The following is a description of a gene set: Genes containing one or more binding sites for (Eed) in their promoter regions (TSS -1000,+100 bp) as identified by GTRD version 20.06 ChIP-seq harmonization. Mouse Gene Set: EED_TARGET_GENES from publication Yevshin I, Sharipov R, Kolmykov S, Kondrakhin Y, Kolpakov F (PMID 30445619) studied in species Mus musculus, and this is the list of marker genes: Otx2, Rab8b, Gm9979, Cers2, 4932441J04Rik, Col13a1, Ret, Ankrd33b, Mymx, Lfng, Nppc, Gfra2, Hrh3, Shisa3, Gm8357, Gm5069, Hand2os1, Gata5, Klf14, Nsg1, Kctd15, Kdm6b, Matk, Kcnk15, Ntn4, Dysf, Gm9884, Nt5c2, Ankrd34b, Slc24a4, Emilin3, Drd5, Gm15723, Hand2, Igf2os, Gnas, Plekhd1os, Fgf5, Gm12198, Foxf1, Nr2f1, D030055H07Rik, Gm29543, Mcidas, mt-Ty, Atxn1, Gm12426, Mcc, Gm11240, mt-Tc, Hmx1, Cacna1c, Gm27032, Cacng4, Tor1aip1, Cacna2d3, Rai14, A830082K12Rik, Cbx2, Fpgs, 3110070M22Rik, St8sia6, Gm13162, Syt2 (NCBI Gene Id 96937), Pak6, Kcnc1, mt-Nd1, Osbpl6, Plxdc2, B4galnt2, H3f4, Ush1g, Six1, Lyzl4, Dipk1c, 1700039E22Rik, Gpr83, Lhx5as1 (NCBI Gene Id 102634380), Ntng1, Irx3os, Slc6a20a, Runx2, Pcdh9, Bhlhe41, Ebf3, 2900005J15Rik, Nr5a1, Tbc1d4, Rasgef1b, Pcdh7, Ctcf, Dll1, Cpne8, Gm2018, Tbc1d30, Rgs10 (NCBI Gene Id 67865), Gata6os, Cacna1g, Rxrg, Prob1 (NCBI Gene Id 381148), Mir8104, mt-Nd2, Zbtb20, Tlcd4, Aspa, Ptger4, Celf4, Itln1, Sema4b, Hoxa9, Adgrl3, Prok2, Slc25a48 (NCBI Gene Id 328258), Prr18, Kcnk9, Elobl, Trp73, Pantr2, Mpp2, Gm14343, Camkk1, Slc30a2, 1700028E10Rik, Nos1, Mir7652, Rnf217, Marveld3 (NCBI Gene Id 73608), Gm13830, A230077H06Rik, Slitrk3, Bcl11a, B130034C11Rik, Metrnl, Zhx2, Slc9a2, Trpc4, 2810032G03Rik, Pear1, Mras, Fibcd1, Adgrb3, Ttc39aos1 (NCBI Gene Id 102642299), Npy, Elfn2, Gm26583, Foxl2, Gm20426, Sp140l2, Nol4, Speg, Fhdc1, Wnt11, Grem1, Cbx3, Vsir, Atp8b1 (NCBI Gene Id 54670), Pianp, Gm16675, Lypd6b, Dchs1, Trim47, Nell1, A730035I17Rik, Hsp90aa1, Flt3, Galnt16, Zbtb46, Ttc34, Ano4, Skor2, Pradc1, Kirrel3, Oxtr, Rasgrf1, Rai1, Gprc5c, Gm10129, Alcam, Syt10, Gm16505, Spag6 (sperm associated antigen 6), Slc35d3, 4930570G19Rik, D430041D05Rik, Adam33, 4930426L09Rik, Slc22a21, Mctp1, Cabp7, 9330154J02Rik, Prdm16os, Vax1, Slc9a5, Eif4g3, Coil, Nipal4, Sntb1, Gm15912, 2900072N19Rik, Tmem121b, Fau-ps2, Cnih3, Plk5, Gm15295, Zar1, Pdgfra (platelet derived growth factor receptor, alpha polypeptide), Emx2, Bahcc1, Gm5660, Dlk1, Esrrg, Rusc1, Nup58, Gfra1, Nwd2os, Hnrnpa2b1, Jakmip1, Gm16793, Gm14207, Paupar, Pcdhac1, 4732414G09Rik, Lhx1, Babam2, Hlx, Fgf13, Slc6a2, Kcnb2, Septin3, mt-Tg, Hspe1, Cxxc4, 9330179D12Rik, Hoxa13, Tagln2, Notum, B230323A14Rik, Gjb6, Wnt2b, Adamts1, Wnt6, 1110032F04Rik, Edil3, Cacna1e, R3hdm2, Gm15469, Cpne7, Irx2, Yaf2, Dio3, Cct8, 4933428G20Rik, Gsc2 (goosecoid homebox 2), Ntsr1, St6gal2, Plcg2, Zfp64, Gm37450, Sco2, Pcdhga9, Gm15825, Trabd2b, Adgrg6, Esrrb, Osbp2, Twist1 (twist basic helix-loop-helix transcription factor 1), Foxred1, Bcl2, Vax2os, Pparg, Bace2, 9130019P16Rik, Twist2, Serinc2, Synpo, Ccdc117, Slc1a2, St8sia2, Efcc1, Ankrd63, Fzd8, Mecom, Hsf4, Tnfaip2, A330008L17Rik, Kcns1, Slc7a2, Otx2os1, mt-Tn, Wnt2, Tmem267, Des, Bmi1, Gm5067, Pgk1, Mmp14, Pou2af3, Zfp451, Lhx2, Ripk4, Nfatc2ip, Slc22a4, Fat4, Bin1, Gm10308, Gm7389, Nxph4, Car10, Ly6k, Duxf1, Cdh8, B230312C02Rik, Npas2, 4930563E18Rik (NCBI Gene Id 75370), Abhd3, Mir375, Hspd1, Gad1, Snhg15, Ltk, 2900052L18Rik, Evi5l, Sox6os, Fam83f, 2610005L07Rik, Mfsd2a, Htra4, Mfsd6, Hoxa4, Gm9767, Inha, Pax6, E130114P18Rik, Pigz, Coa6, A430027H14Rik, Pax1dt, Rsrc1, B3galt5, Bhlhe23 (NCBI Gene Id 319514), Prdm13, Samd5, Fbn2, Srpra, Nfia, Sfrp2, Lysmd2, Nrxn2 (neurexin II), Bmpr1b, Nfatc1, Zeb2, 4930442P19Rik, Prom1, Vstm2a, Fgf12, Nr5a1os, Vipas39, Chrna4 (cholinergic receptor, nicotinic, alpha polypeptide 4), Sox21os1, Satb1, Arid3c, Hoxb6, Tspoap1, Dclk1, BC006965, Adam12, Foxq1, Shox2, Xpnpep3, Adra1b, Gm10222, Kcna2, Yjefn3, Dynll1, Barhl2, Rgs20 (regulator of G-protein signaling 20), Chchd4, A830012C17Rik, Gm5432, Efcab9, Gm16976, Hoatz, Lrp8, Azi2 (NCBI Gene Id 27215), Usp34, 6820431F20Rik, 1700039I01Rik, Samd4, 4732463B04Rik, Eomes, Fbn1, Cnr1, 1700025A08Rik, Ikzf3, Ovol1, She, Gm13425, 4930588K23Rik, Mir124-2hg, Kcnk2, Tshz2 (teashirt zinc finger family member 2), Map3k5, Aff3, Aaas, Lbx1, Gm20387 (NCBI Gene Id 102639169), Ajap1, Sh3rf3, Mcub, Otop1, Grm4, Sox1ot, Crhr2, Hs6st3, Pou3f3, Rgs6, Dab1, Zbtb16, Nfix, Tmem178b, Slit1, Zfp36l1-ps, C1qbp, Trim36, 4933421A08Rik, Cdc42ep3, 2610027K06Rik, Edaradd, Prdm16, Plaat1, Bdnf, Or2a55-ps1, Fcgr3, Hoxa11, Elfn1, Tgfb1 (NCBI Gene Id 21803), Insyn1, Setbp1, Vgll2, Bmp6, mt-Rnr2, mt-Ta, Tmem217rt (NCBI Gene Id 115490131), Mal, Spata31e2, Gm26684 (NCBI Gene Id 102638507), Ccdc3, T, AW047730, Shank3, Gm9962, Vax2, mt-Nd4l, Kcnd3, Col27a1, Otop2, Nptx1, Gpc5, Polg2, Myc, Cenpj, Gabbr2, Wnt10b, Adamtsl3, Foxp1, Gm11536, Fgf18, Sv2c, Gm3242, Hsph1, Pax6os1, Fendrr, Hoxa2, Six3os1, Fam20c, D930007P13Rik, Ints3, Nrn1, Lhx3, Ebf4, Kcnq5, Rbfox3, Otx1, Egflam, Gpr68, Tmem178, Rgl2, H2-K1, Csf1, Ntrk3, Ddx19a, Shisa9, Gm2464, AB041806, Fgf20, Ism1, Hic1, mt-Nd3, 9630013D21Rik, Htr4, Mecomos, Gm26793, mt-Td, Gm17174, Unc5a, Grb10, Plaat5, Cntnap1, Gm26725, Sobp, Sez6l, Foxd1, Hmx3, Cnppd1, Lmna, Egr2, D930020B18Rik, Ubfd1, Antxr2, Ltbp2, Mpp3, Zfp536, Anxa2r2, 4930426D05Rik, Sowaha, mt-Tp, Ace, Cdh4, Mob3b, Smarcd3, Adgra1, 9530059O14Rik, Grin2a, Cd24a, Ripply3, Gm11399, Sim2, Crhr1, Fam217b, Tnfrsf21, Parva, Hoxb3os, Neu2, Tmem200b, Gcnt4, Whrn, Tlx3, Runx3, Hoxaas2, Ptpn5, Epha7, Ank1, Zcwpw2, Trhde, Gm42759, Rspo1, Mir124a-1hg, Prkg2, Pknox2, Sp6, Gm10419, Timp2, Mir124a-3, Tor4a, Sema3d, Ecel1 (NCBI Gene Id 57744), Gm9934, Frem3, Nrp2, Kcna6, Glis3, Lrat, Cdx2, Gm26691, Tbx2, A830092H15Rik, Pantr1, Gm15524, mt-Nd4, Cdh13, Adra2b (NCBI Gene Id 11552), Sec14l2, Gm10069, Gm5814, Gm6556, Pde4dip, Syt6, Gm20646, Pkp1, Ifnz, E030030I06Rik, Lrrcc1, C87436, Lhx6, Spata3 (spermatogenesis associated 3), Unc5c, Grhl2, Unc5d, Shc3, Specc1, Spon1, 0610038B21Rik, Gm9916, Cul9, Kdm6bos, Evx1os, Mir1903, Nlgn1, Zbtb42, Rab20, Nkx1-1, Sphk1, Rasef, Mir34c, mt-Tl1, Prkch, Rbks, mt-Ti, Kif1a, Parp12, Tmtc1, Mlf1 (myeloid leukemia factor 1), Cct3, Gm15958, Lrrtm1, Alox5, Nos1ap, Nrg3 (neuregulin 3), Faah, Fgfr4, Ccnd2, Ahsa1, 9530036O11Rik, Gm13228, Aldh1a3, Wnt7b, Gm29246, Nkx2-2, Atoh8, Foxe3, BC034090, Pals2, Trpc3, Sertm1, Gata3, Plcb1, Ovol2, Gm11762, Htra1, Gm35065, Grid2ip, 9930014A18Rik, Hoxa11os, Itgad, Ebf1, Prox1os, Robo3, Lingo2, Gm2415, Rarres1, Tor1aip2, Gm11201, Osgin2, Gm15564, Clcn4, Tmem132e, Ifngr2, Tal1, Sncaip (synuclein, alpha interacting protein (synphilin)), Nkx3-1, 2610042L04Rik, Rhbdl3, mt-Cytb, Grid1, Pfdn4, Pth1r, Wt1os, Adra1d, Carm1, Stk10, Gm13163, Gm15908, Stat5a, Galr2, Ntrk2 (neurotrophic tyrosine kinase, receptor, type 2), Piezo2, Mir1895, Gm15934 (NCBI Gene Id 102638854), Ramp2, Rcvrn, Efna5, Mir124a-2, Cracd, Ctdspl, Kcnk12, Tfap2e, Inhbb, Sox6, Gm11772, St13, Cbln2, Gm16136, Sv2b, Rreb1, Tmem50b, Astn2, Dnaja4, Dact1, Gm26654, Gm15631, Mir1247, Trim2, Hspa8, Mfsd4a, C530025M09Rik, mt-Tv, Hoxa10, Arhgef4, Susd1, Cavin1, Tmem43, Hapln2, P4ha2, Hoxd11, Ptf1a, Speer4cos, Ttc39a, Gm43391 (NCBI Gene Id 115490167), Tbc1d1, Gm15688, Sdk2, Slc35a5, Fhod1, Gm37047, Ppm1e, Prox1, Dcdc2a, Pcdh15 (protocadherin 15), Prcd, C1qtnf4, Shc4 (SHC (Src homology 2 domain containing) family, member 4), Nxph1 (NCBI Gene Id 214232), Mir5046, Exosc2, Col12a1, Insm1, Mdga1, Gm9945, Gm14285, Mir207, 4833418N02Rik, Ppp2r2b, Gm6934, Ikzf1, Adcy1, Kcnj8, Jph3 (junctophilin 3), Adora1, Spock1, Bik, 0610040J01Rik, Gm12446, Junos, 4930477E14Rik, Obi1, Runx2os1, Gm14204, Gm2990, Mdga2, Hr, Zic4, Fezf2, Bnip3l, Bmper, Ccbe1, En1 (NCBI Gene Id 13798), Pcdhga10, Hoxaas3, Rasgrf2 (NCBI Gene Id 70739), Aqp5 (NCBI Gene Id 11830), Lrrc38, 5730596B20Rik, Irx6, Duoxa2, 8430419K02Rik, Ptprm, Lrrc7, Tsacc, Adamts3, Lyn, Lrp8os3, Gm12576, Tmcc3, Plekhh3, Sgk3, Pgf, Gdnf, Col4a2, Gabrg3, Vamp4 (NCBI Gene Id 53330), Gabra1, mt-Co2, Dgkg, Zfp831, Slc35e2, Gm15496, Gm11789, 1700112D23Rik, Gm10837, Gpr101, Cacna1a, Ache, Pitpnm3, Dnaja1, Stard10, AU022754 (expressed sequence AU022754), Fev, Gm10649, Mir9-1, Htr1b (5-hydroxytryptamine (serotonin) receptor 1B), Tfap2a, Mixl1, Fgf16, Gm10463, Fezf1, Ddr1, Cpd, Mlec, Lhfpl2, Nell2, Gli3, Kpnb1, Rasd2, Hoxd8, Adamts5, Slc8a3, Atp6v1c2, Reln, Gm266, Chst2, Bnc1, Ndrg4, Fgf9, mt-Co1, Hrk, Emx2os, Slc7a4, Lhx9, Sowahd, Gm12339, Nefl, Sox9, Mlkl, Kcnma1, Hs3st6, Vipr1, Dgki, Maf, Atg3, Pde10a, Rtn4rl1, Kcnd3os, Hsp90ab1, Ahrr (NCBI Gene Id 218337), Kcnq4, Pax2, Shroom1, Fgfr3, mt-Tr, Hspbp1, Cdc20b, Gm14964, Sfi1, Slc6a3, Snora9, Apba2, Hnf1b, Nr2e1, Rbm46os, Chadl, Vstm2b, Car7, Trank1, Bnc2, Doc2b, Efhd1, Dlx4os (NCBI Gene Id 320453), Gpr156, Gm13238, Edar (ectodysplasin-A receptor), Arpp21, Vwc2, Aldh1a2, Nalf1, Myl3, Eef1d, Vipr2, Wnt5b, Nrp1, Mir196b, Pxdc1, Kctd12, Gm6085, Gnal, Gls, Nt5e, Kif26b, Penk, A930029G22Rik, Plekhd1, 9030622O22Rik (RIKEN cDNA 9030622O22 gene), Pou4f1, Pcdh1, Fkbp4, 3110082J24Rik, Gm11638, Samd14, Mir449c, Hoxb5, Cdkn2c (cyclin dependent kinase inhibitor 2C), Kbtbd11, Ostm1, Grip2, Nbea, mt-Tm, Foxb1, Arhgap26, Grin1os, Tgfa, Gm12462, Epha8, Tifa, Obsl1, Foxl2os, Cnot6, Zfp385b, Cacnb2, Pax5, Dock10, 1700086L19Rik, Nrxn1, Slc6a17, Egfem1, Mir6236, Mir155hg, Tox2, Rasl10a, Hpca, Mybbp1a, Stip1